The following is a description of a gene set: studied in species Homo sapiens The formation of 2-LTR circles requires the action of the cellular non-homologous DNA end-joining pathway. Specifically the cellular Ku, XRCC4 and ligase IV proteins are needed. Evidence for this is provided by the observation that cells mutant in these functions do not support detectable formation of 2-LTR circles, though integration and formation of 1-LTR circles are mostly normal. The reaction takes place in the nucleus, and formation of 2-LTR circles has been used as a surrogate assay for nuclear transport. It has also been suggested that the NHEJ system affects the toxicity of retroviral infection. part of: Integration of provirus Reactome Pathway: 2-LTR circle formation, and this is the list of marker genes: PSIP1, XRCC4, XRCC5, BANF1, HMGA1, vpr, vpu, rev, gag, gag-pol, vif, LIG4, XRCC6